The following is a description of a gene set: Atrophy of the frontal cortex. Frontal cortical atrophy studied in species Homo sapiens Human Gene Set: HP_FRONTAL_CORTICAL_ATROPHY, and this is the list of marker genes: CYB5R3, MEF2C, SCYL2, VPS13A, POMT2, HIVEP2, CYB5A, AHDC1, GRIA3, SPG11, OPHN1, VCP, PARS2